Given this list of marker genes Ntrk1, P2rx3, Scn11a, Adam11, Scn9a, here is a description of the gene set: Any process that results in a change in the behaviour of an organism as a result of a chemical pain stimulus. studied in species Mus musculus Mouse Gene Set: GOBP_BEHAVIORAL_RESPONSE_TO_CHEMICAL_PAIN